Given this list of marker genes YIPF6, SAR1B, GOLGA8CP, TMEM115, FUT2, SAR1A, RAB34, FUT3, ST6GAL2, TMED3, CHPF2, GOLGA8DP, GOLGA8M, GOLGA6D, SLC30A5, GOLGA8IP, MOB4, COG3, GCC1, MAN2A1, GCNT1, GOLPH3L, ABO, FUT6, NSG1, RAB21, GOLGA8J, FUT5, PITPNM1, A3GALT2, ST3GAL4, GOLGA8K, GOLGA2, GALNT2, CSGALNACT2, B3GALT6, GOLPH3, GOLGA8B, ACP3, HID1, GAL3ST3, TMEM87B, CHSY3, ATL1 (NCBI Gene Id 6681), GOLGA6A, B4GALT2, GPR89A, ATP2C1, GPR89B, XYLT1, GOLGA8H, GOLGA8N, GOLGA8O, LYSET, GOLGA8A, NSG2, B4GALT7, HACE1, CHPF (chondroitin polymerizing factor), INPP5E, ASAP2, B4GALT5, B4GALT1, RAB30, FUT7, GOLT1A, NECAB3, B4GALT3, YIPF1, GOLGA8R, GALNT3, GOLGA6C, SORL1, CSGALNACT1, YIPF2, FUT4, HLA-A, STX16, CANT1, B4GALNT3, PSENEN, FUT8 (fucosyltransferase 8), TMEM87A, GAL3ST2, TMEM59, FUT1, SORT1, TMED2, B4GALNT4, CHSY1, LLGL1, GOLGA8Q, BCAP31 (B cell receptor associated protein 31), ZDHHC14, UXS1, NAGPA, SLC30A7, GOLGA3, ST6GAL1, GOLIM4, GOSR1, ST3GAL2, ST3GAL1, GOLGA6B, GOLGA8S, SCFD1, ST3GAL3, GGTA1, GAL3ST4, GALNT1, GOLGA5, SMPD3, SGMS1, GOLGA8T, B4GALT6, APH1A, here is a description of the gene set: Human Gene Set: GOCC_GOLGI_CISTERNA Any of the thin, flattened membrane-bounded compartments that form the central portion of the Golgi complex. species: Homo sapiens